Given this list of marker genes Grp, Inpp5a, F2, Bicd1, Gpr27, Chga, here is a description of the gene set: Mouse Gene Set: GOBP_REGULATION_OF_PHOSPHOLIPASE_C_ACTIVATING_G_PROTEIN_COUPLED_RECEPTOR_SIGNALING_PATHWAY Any process that modulates the frequency, rate or extent of phospholipase C-activating G protein-coupled receptor signaling pathway. studied in species Mus musculus